Given this list of marker genes AHDC1, CCDC47, FANCB, KATNB1, KMT2C, SLX4, ERCC4, FANCL (FA complementation group L), PMM2, NDN, CHD1, NPAP1, NSD2, MYT1L, BRIP1, BRCA2, RAD51, HERC2, FANCM (NCBI Gene Id 57697), PUF60, HNRNPH2, RFWD3, NSDHL (NAD(P) dependent steroid dehydrogenase-like), PWAR1, FANCI, KAT5, SIM1, GON7, FANCC, SNRPN, DNM1, RNU4-2, IFT74, PWRN1, PUM1, FANCE, AGO1, FANCA, CLCN3, PALB2, MAPK1, SYT1, NAA60, STXBP1, KIF15, FANCF, MAD2L2, LMX1B, SNORD116-1, MKRN3, UBE2T, FANCD2, BRF1, FOXL2, XRCC2, MAGEL2, EHMT1, SNORD115-1, OCA2, PHIP, BRCA1 (NCBI Gene Id 672), ANKRD17, UBE2A, FANCG, RAD51C, RNF2, here is a description of the gene set: Abnormal shape of the palpebral fissure Human Gene Set: HP_ABNORMAL_SHAPE_OF_THE_PALPEBRAL_FISSURE species: Homo sapiens The presence of an abnormal shape of the palpebral fissure.